The following is a description of a gene set: Reactome Pathway: Signaling by PDGF Platelet-derived Growth Factor (PDGF) is a potent stimulator of growth and motility of connective tissue cells such as fibroblasts and smooth muscle cells as well as other cells such as capillary endothelial cells and neurons.The PDGF family of growth factors is composed of four different polypeptide chains encoded by four different genes. The classical PDGF chains, PDGF-A and PDGF-B, and more recently discovered PDGF-C and PDGF-D. The four PDGF chains assemble into disulphide-bonded dimers via homo- or heterodimerization, and five different dimeric isoforms have been described so far; PDGF-AA, PDGF-AB, PDGF-BB, PDGF-CC and PDGF-DD. It is notable that no heterodimers involving PDGF-C and PDGF-D chains have been described. PDGF exerts its effects by binding to, and activating, two protein tyrosine kinase (PTK) receptors, alpha and beta. These receptors dimerize and undergo autophosphorylation. The phosphorylation sites then attract downstream effectors to transduct the signal into the cell. part of: Signaling by Receptor Tyrosine Kinases studied in species Homo sapiens, and this is the list of marker genes: STAT5A, PDGFD, PIK3CB, COL5A1, FURIN, THBS3, RAPGEF1, CRK, HRAS, COL9A1, NCK1, STAT5B, COL4A5, COL9A3, PDGFA, COL3A1, COL6A3 (collagen type VI alpha 3 chain), COL4A2, COL6A1, SRC, PDGFRA, COL6A2, PTPN12, COL4A3, PIK3R1, GRB7, THBS2, NCK2, STAT1, COL4A1, PTPN11, PDGFRB, CRKL, PIK3R2, PDGFB, STAT6, PLG, STAT3, COL9A2, PLCG1, PLAT, THBS1, COL2A1, COL5A3, GRB2, COL5A2, THBS4, SOS1, PDGFC, NRAS, PIK3CA, BCAR1, KRAS, SPP1, COL6A6, COL4A4, RASA1, COL6A5